The following is a description of a gene set: studied in species Homo sapiens from publication Prots I, Skapenko A, Lipsky PE, Schulze-Koops H (PMID 21347372) Human Gene Set: GSE24634_NAIVE_CD4_TCELL_VS_DAY5_IL4_CONV_TREG_DN CD25+ regulatory T cells develop in the thymus (nTregs), but may also be generated in the periphery upon stimulation of naive CD4 T cells under appropriate conditions (iTregs). The mechanisms that regulate the generation of peripheral iTregs are largely unknown. We used microarrays to gain insights into the molecular program of extrathymic Treg development. Genes down-regulated in comparison of naive T cells at day 0 versus CD25+ regulatory T cell (Treg) treated with IL4 at day 5., and this is the list of marker genes: PREB, HSPD1, CD74, MED20, AFG3L2, ACTB, EPRS1, UBE2L3, PDIA5, UCHL3, NTHL1, CCT7 (NCBI Gene Id 10574), MYB, NEDD9, UBE2N, PPP1R8 (protein phosphatase 1 regulatory subunit 8), CALML4, HSPA2 (NCBI Gene Id 3306), LARS2, HSPA14, ETF1, CYCS, CCNE2, UGGT1, CTNS, DNAJC17, ACADVL, MRPS2, DPP3, HK1, MREG, PAGR1, PSMB5, RRP15, DDB2, RTP4, PFDN2, ARL3, CAD, MARS1, PUS7, TNFRSF8 (TNF receptor superfamily member 8), FANCE, HMGA1, CASP7, GINS4, RAD1, FAM136A, BLVRA, UTP14A, NOC3L, GSS, THOC6, RBM28 (RNA binding motif protein 28), NDUFAF1, HSPE1, NOP16, SLC25A32, DNAJA1 (NCBI Gene Id 4737), AIMP2, PTRH2, NDUFC2, TMPO, CCT2, DUS4L, SGCB, GRAP2, HSPA8, KIF3A, RAB8B, ETNK1, GTPBP4, NAT10, FERRY3, DERL1, SLC39A7, BATF, SIVA1 (SIVA1 apoptosis inducing factor), UBE2K, WDR18, SLC25A11, TRAF1, NDUFB3, NDUFA8, RPL26L1, KPNB1, UBE2S, ACO2, DKC1, DDX56, BRCA1, HDGF, SLC25A5, NDC80, NF2, RABIF, HEATR1 (NCBI Gene Id 55127), ATP6V1C1, MUS81, CIAO1, FAM98A, DOHH, RNF14, COQ7, ACAT1, ITCH, PSMC4, NEIL3, POLE2, ATP6V0B, MELK, SEC23B, PSMC2, CASP3, BLVRB, RBPJ, CCT3, CNP, RAD50, LONP1, CDK5, ACSL5, C1QBP, P4HA2, GMPS, GPN3, ORMDL2, NCAPD3, CD38, CYB5B, SLC31A1, GSTO1, COASY, CSNK2A1 (casein kinase 2 alpha 1), IDH2, RCC1 (regulator of chromosome condensation 1), CAPZA1, MRPL16, KHSRP, PHB1, ILVBL, RWDD2B, RANGAP1, DNM1L, PPIA, G3BP1, EPAS1, PRKAG1, NARS2, NAA10 (NCBI Gene Id 8260), DNAJC9, ABTB2, GLO1, RNF187, HSD17B10, CENPE, ICMT, PLPP1, AASDHPPT, ATG3, CRELD2, GTDC1, MCAT, SLBP, KDELR2, TMEM165, IMMT, PSMG1, CLPP, ATP6V1D, PPAT, TEFM, POMP, SYT11, TIMM17A, WDR12, ANAPC1, ACOT13, PPP1R14B, KNTC1, IDH1, ERLIN1, EMG1, PALS2, NUDT21, AHSA1, CMTM6, CISD1, TBL2, NAPG, FHL2, DDX39A, MPP1, NUDT6, AVEN, PPA2, EXTL2, ALDH3A2, MANF, WARS1